Given this list of marker genes Slc8b1, Micu1, Stoml2, Yme1l1, Micu3, Mcu, Mcub, Spg7, Phb1, Parl, Maip1, Smdt1, Afg3l2, Micu2, Pmpca, Phb2, Pmpcb, here is a description of the gene set: Mouse Gene Set: REACTOME_MITOCHONDRIAL_CALCIUM_ION_TRANSPORT Mitochondrial calcium ion transport species: Mus musculus